Given this list of marker genes MLYCD, ATXN10, DNAJB6, SGMS1, NAB2, SERINC1, PHLPP1, SEH1L, NAA15, TBCE, ACTG1, MAP3K8, PRPS1, MATK, CCRL2, TOP1, GARRE1, CBX2, CMBL, NFYA, RAPGEF5 (NCBI Gene Id 9771), RLIM, EFR3A, PAF1, RPS19, TLNRD1, E2F6, KITLG, RAI1, EIF3E, ETS1, PRKAR1A, CEBPG, DUSP1, ADCK5, FAAP100, SLC25A13, RPL4, CYTH3, SLC35A3, EYA4, SS18, PANK3, DSEL, MMD, LARP7, ZNF516, PSPC1, GPNMB, P2RY10, UHRF2, CD300LB, MFHAS1, MOB4, ZNHIT6, RPL23A, HACD2, TMC6, NDUFAF7, JUND, PHF13, CHD8, GTF2B, CD68, FZD7, CMPK1 (cytidine/uridine monophosphate kinase 1), ZNF281, SYNGR1, SEPTIN10, TAL1, CAPN2, SULF2, TLE1, FOXM1, RPL37A, RPL7, CYTIP, POLR1F, GPSM1, KDM3A, LRP1, BMPR2, TBCA, WDR45B, ZNF608, KXD1, ECT2, UBE2G1, C5orf24, PJA2, ERAL1, MED7, ANKRD49, MARK3, TFAM, PADI2 (peptidyl arginine deiminase 2), ARHGAP22, ZNF746, SLK, MIF4GD, DGKG, FXYD5, UBQLN1, ARHGAP26, SPIN1, ZNF579, RAB32, RPL27A, SH2B2, YWHAH (NCBI Gene Id 7533), ARFGEF3, DCAF10, LSP1, HMGA2, ATXN7L3B, FYN, RNGTT, ZNF449, NDFIP2, NAV2, LMBRD1, WDR43, LYPLAL1, RTN4, IRS2 (NCBI Gene Id 90066), ZCRB1, MTSS1, NBEAL1, OPTN, ARL2BP, BAMBI, AMFR, RRP1, RDH10, COX7A2L, BEX3, FAR1, PDLIM5, KIF11, PDIK1L, DNAJA2, ANKH, PDCL3, UCHL3, FBXL3, STRN3 (striatin 3), SENP2, CD83, BCKDK, RPS7, EMP1, KCNQ1OT1, GNA13, PPP6C, ZRANB3 (zinc finger RANBP2-type containing 3), BCAR3, SMAD5, CDK14, SEC62, SEMA6D, RNF146, FUT10, BASP1, PUM3, TSPAN13, GNL2, APPL1, KCNK12, BPNT2, MSRA, MAP4K5, ELAVL1, LGALS1 (galectin 1), PLXNC1, HIVEP1, PRRC1, RGS1, STYX, C6orf62, PPM1A, RPS3, TCEAL1, SNHG17, PEX5, JPT2, UBE2B, NOSTRIN, NEAT1, TSC1, MND1, TERF2IP, STBD1, PRPF6, CD84, CA3 (NCBI Gene Id 761), ZFP36, TCEAL9, PRDM2, CENPT, here is a description of the gene set: Temporal analysis of B cell activation in vitro using CD40L and IL-2/4/5 cytokines in wild type Irf4+/+ B cells or in mutant Irf4-/- B cells harboring a tet-inducible allele of Irf4. IRF4 expression was restored, or not, in the Irf4-/- background by culturing in the presence of low or high concentrations of doxycycline. The results provide insight in the role of IRF4 expression levels in coordinating different programs of B cell differentiation. species: Homo sapiens Genes up-regulated in CD40L and IL-2 IL-4 IL-5 stimulated at day 3 B cell IRF4high versus CD40L and IL-2 IL-4 IL-5 stimulated at day 3 B cell wildtype. Human Gene Set: GSE46606_IRF4HIGH_VS_WT_CD40L_IL2_IL5_DAY3_STIMULATED_BCELL_UP from publication Ochiai K, Maienschein-Cline M, Simonetti G, Chen J, Rosenthal R, Brink R, Chong AS, Klein U, Dinner AR, Singh H, Sciammas R (PMID 23684984)